Given this list of marker genes SFPQ, MACROH2A1, DDX11, BUB1, FEN1, SLF1, RAD21, SMC5, NSMCE2, SLF2, here is a description of the gene set: Human Gene Set: GOBP_POSITIVE_REGULATION_OF_SISTER_CHROMATID_COHESION Any process that activates or increases the frequency, rate or extent of sister chromatid cohesion. species: Homo sapiens